Given this list of marker genes Ywhaz, Psma5, H2bc1, Dna2 (NCBI Gene Id 327762), Psmd7, Cdk1, Wrn, Psmc4, Rnf168, Orc3, Kat5, H4c1, Ccnb1, Psmb6 (NCBI Gene Id 19175), Pkmyt1, Rad9b, H2bc13, H2bc3, Gtse1, Ywhab, Uimc1, H4c9, Rfc5, Blm, Rad9a, Cdc45, Wee1, Mcm2, Chek2, H4c14, Mcm5, Rpa3, Chek1, Psmd6, Psmd1, H2bc8, Psmd8, Rmi2, Mcm3, Ube2v2, Rhno1, Cdk2, Rfc4, Psmd11, Psmc6, H4c4, Rps27a, Rnf8, Orc1, H4c8, Mcm6, H2ax, Ccnb2, Cdc6, H2bc23, Rpa1, Rad17, Rmi1, H2bc12, Psma1, Ywhah, Mre11a, Pias4, Psmd14, H4c17, Mdc1, Psmb1, Psmd12, Ywhae, Orc2, H2bc9, Bard1, Rbbp8, H4c2, H2bc7, Abraxas1, H2bc14, Orc5, H2bc11, Orc4, Topbp1, Psmb4, Mcm4 (minichromosome maintenance complex component 4), H2bc22, Dbf4, Brip1, Mcm10, Herc2, H2bc21, Adrm1, Top3a, Psmc5, Clspn, Ccna2, Nbn, Ywhag, Rfc3, Exo1, Psma7, Ubc, Psmc1, Rfc2, Psmb5, Psmc3, Psma6, Ywhaq, H4c18 (NCBI Gene Id 319161), Brca1, Psma4, Brcc3, H4c12, Uba52, Rad1, H2bc6, Hus1, Babam1 (BRISC and BRCA1 A complex member 1), Rpa2, H2bc26 (H2B clustered histone 26), H2bc15, Orc6, Ube2n, H4c11, Cdc25a, H4c3, Atm, Psmc2, Cdc7 (NCBI Gene Id 12545), Psmb2, Mcm7, H4c16, Rad50, Babam2, Ccna1, H4c6, Psmb7 (NCBI Gene Id 19177), Psma2, Psmd2, H3f4, Uba52rt, Ubb, H2bc24, Cdc25c, Psma3, Mcm8, Sfn, Trp53, Psmd13, Psmd3, Atrip, Psmb3, Nsd2 (nuclear receptor binding SET domain protein 2), H2bc4, Trp53bp1, here is a description of the gene set: G2/M Checkpoints Mouse Gene Set: REACTOME_G2_M_CHECKPOINTS studied in species Mus musculus